Given this list of marker genes RAF1, AGFG1, PKP2, NES, KRT28, SOD1, KRT16, KRT10, KRT80, KRT40, ATP8A2, PKP1, CLN8, KRT72, KRT6B, AGFG2, KRT3, PRPH, GFAP, CSNK1A1, BFSP1, KRT78, KRT71, KRT35, KRT37, KLHL24, MACF1, KRT15, KRT17, ATF2, KRT7, KRT24, KRT76, KRT18, KRT25, BBLN, KRT9, PLEC, TCHH (NCBI Gene Id 7062), KRT31, KRT86 (keratin 86), DSP, KRT4, KRT27, NEFH, EPPK1, KRT83, ERBIN, KRT77, SHH, KRT38, KRT84, KRT6A, KRT5, NEFM, TOR1A, BFSP2, ARHGEF28, KRT2, KRT26, SYNM, DST, NEFL (NCBI Gene Id 4747), PPL, KRT14, KRT33B, KRT75, KRT19, KRT82 (keratin 82), KRT12, KRT74, KRT6C, NDEL1, KRT23, DNAJB6, KRT13, KRT33A, KRT36, KRT1, FAM83H, INA, KRT20, KRT34, KRT85, KRT79, VPS54, KRT81, KRT39, SYNC, KRT32, KRT73, ATXN3, MTM1 (myotubularin 1), EVPL, DES, EVPLL, VIM, here is a description of the gene set: species: Homo sapiens Any cellular process that depends upon or alters the intermediate filament cytoskeleton, that part of the cytoskeleton comprising intermediate filaments and their associated proteins. Human Gene Set: GOBP_INTERMEDIATE_FILAMENT_BASED_PROCESS